The following is a description of a gene set: from publication Lund R, Aittokallio T, Nevalainen O, Lahesmaa R (PMID 14607935) Th1 and Th2 cells arise from a common precursor cell in response to triggering through the TCR and cytokine receptors for IL-12 or IL-4. This leads to activation of complex signaling pathways, which are not known in detail. Disturbances in the balance between type 1 and type 2 responses can lead to certain immune-mediated diseases. Thus, it is important to understand how Th1 and Th2 cells are generated. To clarify the mechanisms as to how IL-12 and IL-4 induce Th1 and Th2 differentiation and how TGF-beta can inhibit this process, we have used oligonucleotide arrays to examine the early polarization of Th1 and Th2 cells in the presence and absence of TGF-beta after 0, 2, 6 and 48 hours of polarization. Genes down-regulated in CD4 T cells activated by anti-CD3 and anti-CD28: IL-12 (2h) versus IL4 (2h). Human Gene Set: GSE2770_IL12_VS_IL4_TREATED_ACT_CD4_TCELL_2H_DN species: Homo sapiens, and this is the list of marker genes: SPINK14, SOX14, TEX13A (NCBI Gene Id 56157), RPRM, SEC14L5 (SEC14 like lipid binding 5), VWA5B1, SDK1, SMYD5, VWF, TMPRSS11BNL, RNF19B, SPAG1, TMEM54, SELPLG, ZPBP (NCBI Gene Id 91091), SCO1, SLC39A14, TREML4 (triggering receptor expressed on myeloid cells like 4), DNAAF10, SF3A2, TDRD7, SLC16A4, TNFSF15, TMUB2, VPS8 (NCBI Gene Id 23355), TNFRSF21, TNR, ZBTB16, TRIM69, RUNX3, TPCN1, TAAR1, ZFYVE26, XRN2, SMPX, TDRD6, SLC47A1, SEMA5A, TGM1, TMEM214, TAAR6, SNAP91, SPNS2, TSSK1B, SLC7A5, MIEF1, TMEM86B, SPRED3, SCAMP1, SLC22A14, VWA5A, ZFYVE28, STMN1, UPP2 (NCBI Gene Id 151531), SPINK13, RNF14, TXN2, SNPH, TUSC3, TSEN54 (NCBI Gene Id 283989), SLC1A5, ZAP70, TM2D1, TMEM60, S100A8, SLC27A4, ZNF394, MYMK, TAS1R1, SLC17A8, TRIM37, TYR, VPS11, SH2D6, SPINK6, STX17, SIX3, YPEL2, TWSG1 (twisted gastrulation BMP signaling modulator 1), SGIP1, SLC4A8, ST8SIA6, RPAIN, TMEM127, SERPINA5, SAMD3, WFDC2, RRP12, TOLLIP, STARD3NL, SI, ZSCAN2, SEZ6L, UMODL1, TUBGCP6, RNF214, SFRP5, SERPINA7, TBR1, TCF15, WNT7B, SAMD4A, TNFSF14, WDR36, SETD6 (SET domain containing 6, protein lysine methyltransferase), ZC3HC1, TRAPPC2L, TAF15, TATDN2, UROS, TCTN3, TTF1, TMEM115, TRMT2A, WDR82, TPPP, TSKU, SPAG4, TBC1D22A, ST6GALNAC5, STX1A, TMEM37, RPL28, VAPA, TMED1, NALF2, CAPN15 (calpain 15), TTBK2, UNC5D, SHH, TCTN2, TBK1, TLR3, TEKT3, TWIST2, RPL10L, SNAP25, TMEM165, TNNI1, SEPTIN1, UBQLN4, S100A9, XPOT, TUBD1, SHISA6, UPP1, VWC2, TBCB, TCIRG1, SPATA19, TNNI3, TDRD5, RUFY4, STIM1, STAP1, SLC46A3, RNASEL, SSR1, XAB2